The following is a description of a gene set: species: Homo sapiens Any process that activates or increases the frequency, rate or extent of vitamin D receptor signaling pathway activity. Human Gene Set: GOBP_POSITIVE_REGULATION_OF_VITAMIN_D_RECEPTOR_SIGNALING_PATHWAY, and this is the list of marker genes: MN1, RXRA, RXRB, CYP27B1, VDR, SNW1